Given this list of marker genes Septin1, Brca2, Zwint, Knl1, Mlh1, Cenpc1, here is a description of the gene set: species: Mus musculus A chromosome localization process whereby chromosomes are positioned in a specific order and orientation at the metaphase plate (spindle equator), during meiotic chromosome segregation. This alignment ensures that each daughter cell will receive the correct number of chromosomes during cell division. Mouse Gene Set: GOBP_MEIOTIC_METAPHASE_CHROMOSOME_ALIGNMENT